Given this list of marker genes ATP6V1B1, PAXIP1, NEXMIF, CIRBP, MYOF, STXBP5, USP8, SLC10A7, RPL28, SH2B3, SRSF4, STUM, NCBP3, TCHH, CINP, APLN, PGR, WIZ, FA2H, RUNX1T1, EMILIN3, KIAA1549L (NCBI Gene Id 25758), BRD8, RIC8B, NFATC3, ASB7, PCDH17, PGAP1, ARID5B, CBLB, SMCO1, SH3RF1, NME6, SLC9A8, ADGRG6, SERPINB4, EIF3J, MAPRE1, SYCE1, ZNF410, PRF1, SPATA2L (NCBI Gene Id 124044), TNRC6A, SH3BP1, VEPH1, JAKMIP2, LOXL3, RAB5C, PTPRT, PTGDR, SPOCK3, FAF2, GPR63, CLDN10, NECTIN1, EBF3, LIMS2, RAD51B, TMEM196, CERS6, FCN1, LRAT, ETV5, VWF, SCLY, AQP6, ZNF546, SERPINB3, LDHD, OLFML1, here is a description of the gene set: Genes predicted to be targets of miRBase v22 microRNA hsa-miR-4296 in miRDB v6.0 with MirTarget v4 prediction scores > 80 (high confidence targets). species: Homo sapiens from publication Chen Y, Wang X (PMID 31504780) Human Gene Set: MIR4296